The following is a description of a gene set: species: Homo sapiens Interleukin-1 family signaling Human Gene Set: REACTOME_INTERLEUKIN_1_FAMILY_SIGNALING, and this is the list of marker genes: IRAK3, IL37, IL1B, NFKB1 (NCBI Gene Id 4790), TIFA, IL1RN, UBB, PTPN20, PSMD14, IL18RAP, ALOX5, PSMA3, PELI3, RELA, UBE2N, SMAD3, PSMD12, LRRC14 (leucine rich repeat containing 14), PSMD13, TNIP2, FBXW11, STAT3, S100B, RBX1, TP53, RIPK2, AGER, PSMD11, IL1RAPL1, TAB3, TAB2 (TGF-beta activated kinase 1 (MAP3K7) binding protein 2), MAP2K6, NLRC5, IL1A, IL1RAP, N4BP1, SKP1, PTPN23 (NCBI Gene Id 96248), UBA52, IRAK4, MAP3K3, RPS27A, PTPN6, PTPN5, CASP8, PTPN2, IL1RL2, NFKBIA, PSMB4, PELI2 (NCBI Gene Id 93480), PSMB6 (NCBI Gene Id 95505), PTPN9, IRAK2, IL13, CASP1, PSMC1 (NCBI Gene Id 5700), PSMB5, PSMB7, IL36G, ADRM1, S100A12, NLRX1, IL18, PTPN4, PSMA2, IL36B, PSMC3, PSMC6, PSMD6, USP14, CTSG, MYD88, MAP2K4, PSMA7, PSMD8, PSMA4, NOD2, IL18BP, IKBKB, NFKB2, UBE2V1, IL33, APP, PSMD3, HMGB1, PSMD7, MAP3K8, PSMC5, GSDMD, TRAF6, PSMB3, BTRC, TRAF2, TOLLIP, NKIRAS1, USP18, CHUK, MAPK8, SIGIRR (NCBI Gene Id 59307), NOD1, SAA1, PSMA6, PSMD2, PTPN13, PTPN11, IL1F10 (interleukin 1 family member 10), NKIRAS2, TBK1, MAP3K7, PSMA5 (NCBI Gene Id 5686), PSMB1, IL1R2, PTPN12, IL4, PSMA1, MAP2K1, CUL1, UBC, SQSTM1, PSMB2, IL1RL1, PTPN18, PSMD1, IRAK1, IL1R1, IL18R1, PSMC4, TAB1, IL36RN, IKBKG, IKBIP, PELI1, PTPN7, PSMC2, PTPN14, IL36A, NFKBIB, ALPK1, SEM1